The following is a description of a gene set: Mouse Gene Set: GOBP_VALINE_METABOLIC_PROCESS The chemical reactions and pathways involving valine, 2-amino-3-methylbutanoic acid. species: Mus musculus, and this is the list of marker genes: Bcat2, Acad8 (NCBI Gene Id 66948), Bcat1, Hibadh, Aldh6a1, Bckdk, Hibch (3-hydroxyisobutyryl-Coenzyme A hydrolase), Ilvbl